The following is a description of a gene set: Hyperammonemia An increased concentration of ammonia in the blood. Human Gene Set: HP_HYPERAMMONEMIA species: Homo sapiens, and this is the list of marker genes: RINT1, ASL, MMUT, PCCB, UQCRH, ACADM, ACAD9, TSFM, ATPAF2, PDHB, MTO1, LRPPRC, CYC1, GLUD1, SLC25A15, MRPS22, MT-ATP8, GLUL, SLC22A5, FBXL4, UQCRC2, FOCAD, NAGS, DLD, BTD, SERAC1, OTC, SLC7A7, STX5, MMAA, TUFM, ATP5F1A, ACAT1, PCCA, ATP5F1D, ATP5F1E, CPT2, HSD17B10, EIF2AK3, MARS1 (NCBI Gene Id 4141), IVD, SC5D, ACADVL, ALG11, ALDH18A1, CAD, MRM2, ATP5MK, MCCC1, CPS1, SLC25A20, SLC25A42, SLC25A13 (NCBI Gene Id 10165), ASS1, MPV17 (NCBI Gene Id 4358), COX6B1, TANGO2, ATP5F1B, GOT2, MCCC2, IARS1, NDUFA6, MMACHC, COQ4, NR1H4, MECP2, CPT1A, NBAS, RRAGC, HADHA, CARS2, TMEM70, AASS, HADHB, HLCS, CA5A, ARG1, SLC25A36, HADH, HMGCL, MMAB, MT-ATP6